Given this list of marker genes ADA, UMPS, PRPS2, HPRT1, PAICS, GART, TYMS, PRPS1, ADK (NCBI Gene Id 132), GMPS, IMPDH2, APRT, here is a description of the gene set: Cell cycle (KEGG, GenMapp). Human Gene Set: MODULE_56 species: Homo sapiens